The following is a description of a gene set: species: Homo sapiens Genes down-regulated in fibroblasts from old individuals, compared to those from young donors. from publication Ly DH, Lockhart DJ, Lerner RA, Schultz PG (PMID 10741968) Human Gene Set: LY_AGING_OLD_DN Messenger RNA levels were measured in actively dividing fibroblasts isolated from young, middle-age, and old-age humans and humans with progeria, a rare genetic disorder characterized by accelerated aging. Genes whose expression is associated with age-related phenotypes and diseases were identified. The data also suggest that an underlying mechanism of the aging process involves increasing errors in the mitotic machinery of dividing cells in the postreproductive stage of life. We propose that this dysfunction leads to chromosomal pathologies that result in misregulation of genes involved in the aging process., and this is the list of marker genes: CENPF, CTSC, HMGN2, CCNB1, PSMD12, PPP1CC, NASP, CENPA, PTGS2, H2AZ1, FBL, CDH11, RANBP1, UGCG, CDC20, HAS2, MYBL2, POSTN, TYMS (NCBI Gene Id 7298), CCNA2, PSMC2, CSE1L, PCNA, NUP88, PSMA2 (proteasome 20S subunit alpha 2), KIF2C, UBE2C, CKS1B (CDC28 protein kinase regulatory subunit 1B), FBN2, CDC25B, PSMC6, SAFB, FOXM1, MCM2, TGFBR2, CKAP5, CCNF, NAE1, HMGB2, KIF23, KIF11, HSD17B10, DDX39A, PSMA3, SERPINB2, KIF14, PKMYT1, PAFAH1B1, H2AX, PSMD11, PLK1, PARP1, CDK4, CXCL8, BARD1, ATR